Given this list of marker genes SACS, RBL2, SCN1A, PAX7, CACNA1A, ATP1A2, SOX3, ITPR1, GCH1, FGF14, PRRT2, BEAN1, SYT14, KCND3, GRM1, CACNA1G, UROC1, THG1L, here is a description of the gene set: Gaze-evoked horizontal nystagmus Horizontal nystagmus made apparent by looking to the right or to the left. species: Homo sapiens Human Gene Set: HP_GAZE_EVOKED_HORIZONTAL_NYSTAGMUS